The following is a description of a gene set: from publication Chen Y, Wang X (PMID 31504780) Genes predicted to be targets of miRBase v22 microRNA mmu_miR_6946_3p in miRDB v6.0 with MirTarget v4 prediction scores > 80 (high confidence targets). Mouse Gene Set: MIR_6946_3P species: Mus musculus, and this is the list of marker genes: Ttc23, Csnk1g1, Klf6, Arid1b, Kdelr1 (NCBI Gene Id 68137), Ppp4c, Lhx5, Dtx3l, Hesx1, Ercc6, Lpin2, Tmem30a, Syt11, Fgf20, Ceacam2, Zmynd8, Kcnj16, Pwwp2a, Tfec, Washc4, Oca2, Kmt2a, Gdf2, Crbn, Phactr3, Nars2, Nefh, Desi2, Rbmyf3, Dusp13b, Vim, Crppa, 1110004F10Rik, Ptger2, Nptx1, Fgf12, Pabir2, Ralgapb, Ap1m2, Fam20b, Svil, Zfp935, Tmed5, Rbm41, Ppp4r3a, Zranb2, Scn9a, Smad3, Gtf2h1 (NCBI Gene Id 97364), Plod2, Mtap, Morf4l2, Itgb3bp, Nmur2, Selenot, 4921539E11Rik, Rabgap1l, Atg12, Dpysl3, Chd6, Nrep (NCBI Gene Id 27528), Nrg3, Hivep3, Lin54, Chst2, Armh4, Rps6kb1, Virma, Cdh1, Kif26b, Akap17b, Anks1b, Ubr5, Arpp21 (NCBI Gene Id 94243), Arrdc3 (NCBI Gene Id 105171), Arhgap26, Emp2, Trim71, Cacna1c, Lgi2, Tmprss11e, Tmprss15, Crebrf, Cysltr1, Klhl9, Amer1, Rbpms2, Zfp91, Clec1a, Vezt, Zfp106, Usp27x, Setd7, Strbp, Grik1, Siae, Kif1b, Cxxc5, Rhoj, Nr2c1, Scd4, Adtrp, Map3k2, Itga9, Lgi1, Zdhhc12, Slc8a1, Tial1, Ankmy2 (ankyrin repeat and MYND domain containing 2), Polr2m, Tcaim, Wwc2, Sp3, Fpgt, Akap11, Purb, Kctd21, Dnajc9, Maml1, Elp1, Tab3, Egr1, Nlk, Tet3 (tet methylcytosine dioxygenase 3), Hapln1, Ptbp3, Plaat1, Chrm2, Keap1, Csgalnact2, Dph3, Map3k20, Rspo3, Nhlh2, Atp8b1, Grem2, Tspan5, Ulk2, Unc13c, Ints10, Fat3, Galnt7, Smo (NCBI Gene Id 319757), Dgkk, Rsf1, Acsl1, Ascl1, Rbmyf2, Adipor1, Nr1h5, Mitf, Reep1, Lmo4, Tnrc6b, Larp1, Rgs13, Slc5a7, Xpo1, Aadat, Lpar3, Nfrkb, Riox2, Snx27, Alk, Sgip1, Fgf10, Cxxc4, Gcm1, Sema3a, Rgs17, Rbmyf7, Tigd4, Slc1a2, Gli3, Sh3bgrl2, Cavin2, Necab1, Slc22a30, Nedd1, Cdk2ap1, Nexmif, Rufy3, Neto1, Plekha7, Prkcq, Tafa1, Ubn2, Trp53bp2, Eea1, Rnd1, Ankrd34b, Esyt2, Cdh20, Kcnd2, Usp30, Ffar3, Dcc, Cops2, Hars2, Kcnj6 (potassium inwardly-rectifying channel, subfamily J, member 6), Zfp148, Adamts6, Nrxn3, Eif2s1, Zfp518b, Cdh12, Yod1, Kdsr (3-ketodihydrosphingosine reductase), Thsd7a, Ttll7, Satb2, Slc22a28, Zpr1, Golim4, Lrp6, Lamp2, Mtpn, Tmem161b, Tc2n, Eif4e3, Chst11, Prpf18, Cd83, Poglut3, Elavl4, Atp2b2, Snapc1, Car10, Braf, Ammecr1, Tln2, Synrg, Grhl2, Btg3, Bend3, Ccpg1 (NCBI Gene Id 72278), Pmch, Ocrl, Cplx2, Cd28, Pan3, Col8a1 (collagen, type VIII, alpha 1), Pnma2, Gxylt1, Epg5, Patz1, Elovl6, Pank3, Klhl4, Ergic2, Slc5a1, Ndufb11b, Fbxo45, Slc5a3, Cutc, Dram2, Ank3, Rbmyf9, Ralgapa2, Gatd3a (glutamine amidotransferase like class 1 domain containing 3A), Zfp595, C87436, Aplf, Adamts3, Lrig2, Katnal1, Col4a4, Arl5a, Mal (myelin and lymphocyte protein, T cell differentiation protein), Fhip1b, Samt4, Epha5, Plekhh3, Elk3, Niban1, Mrpl50, Cpeb3, Cacna2d1, Ankrd17, Thrb (thyroid hormone receptor beta), Depdc1a, Prtg, Fxr1, Avl9 (AVL9 cell migration associated), Cop1, Rbmyf6, Klrk1, Timp3, Nhsl2, Macroh2a2, Ttbk2, Psmd10, Unc5c, Ddr2, Tmcc3, Gpr55, Tcf12, Kctd9, Rbmyf8, Ppargc1b, Fam98a, Irs4, Dld, Fbxl5, Jagn1, Tsbp1, Sdr16c5, Tmem207, Lsamp, Rbmyf1, Tox3, Rbms3, Zfp697, Pcdh17, Mdga2, Nr0b1, Flg2, Ago1, Senp7, Rorb, Mon2, 1700020L24Rik, Zkscan1, Togaram1, Gabrg1, Mef2c, Btrc, Lrrc8e, B3galt1, Necap1, Lhx8, Dync1li1, Ybx3, Syn2, Bcl2, Spop, Il36rn, Col27a1, Ybx1, Ilrun, Cachd1, Kcnk2, Glud1, Cdk12, Fmr1, Kctd11, Pdlim5, Azi2, Man2a1, Brpf1, Strap, Atxn7, P2ry1, Arnt, Tnrc6c, Slc40a1, Eif3e (NCBI Gene Id 16341), Rnd3, Gm11541, Cpeb2, Pcsk5, Rbmyf5, Rptn, Spred1, Smc1b, Kctd5, Zmat1, Nipa1, Fam124a, Phf14, Bicd2, D16Ertd472e, Kpna4, Acsm2, Nrk, Il22b, Cd84, Cadm2, Pknox2, Atg16l1, Pou2f1, Msl1, Neu4, Fut9, Lysmd3, Arid4b, Crim1, Lamc1, Map2k3, Ikzf2, Zfhx3, Ifi208, Raph1, Pigr, Mpz, Ppp1r9a, Rfx6, Axl (AXL receptor tyrosine kinase), Has2, Cfap58, Slc10a2, Clic5 (NCBI Gene Id 70662), Ptchd4, Prps1, Pou6f2, Setd1b, Tmed8, Robo2, Tstd2, Aass, Cmtm4, Tnfaip3, Rif1, Ifi44, Cfap74, Hipk1, Kctd7, Arpc5, Nedd4l, Invs, 2510009E07Rik, Rbmy, Itsn1, AI593442, Commd2, Zfp811, Dcaf7, Sgk3, Suv39h2, Trim65, Fam174a, Tslp, Synpr, Col6a3, Ttc14, Celf4, Sox9 (SRY (sex determining region Y)-box 9), Chsy3, Ceacam1, Trps1, Sec14l3, Ehd4, Slc33a1, Oprk1, Ddx52, Rfx7, Pomgnt1, Tubgcp4, Fas, Dlg3, Fgfr1op2, Usp15, Fnd3c2, Tmem199, Cxadr, Suz12, Ccdc70, Kcnj2, Pacsin1, Dtwd2, D630045J12Rik, Lrrn1, Hoxc13, Atp5f1c, Kcnc2, Gas1, Cp, Ccdc85a, Hjurp, Plekha8, Ttf1, Pcyox1l, Plxna4 (NCBI Gene Id 330281), Jkamp, Dmtf1l, Kcnma1, Vnn1, Rreb1, Dpyd, Usp13, 9330182O14Rik, Klhl14, Rab3c, Zfp606, Gpr101, Astn1, Tox4, Tns1 (NCBI Gene Id 98418), Kitl, Nfkb1, Ift80 (intraflagellar transport 80), Frrs1l, Cntln, Tmem129, Mfhas1, Smpd3, Flrt2, Dnajc5, Nabp1, Gsk3b, H2-T5, Ddx6, Thbs2 (thrombospondin 2), Trabd2b, Il22ra2, Stxbp5l, Tardbp, Mmp16, Gucy1a2, Trpm3, Cpsf2, Hunk, Dach1, Mbp, Prrx1 (NCBI Gene Id 98443), Slc25a5, Igf1, Cisd1, Ssbp2 (single-stranded DNA binding protein 2), Ms4a7, Ntsr1, Clec2m, Nvl, Prorsd1, Dusp13a, Gng10, Met, Cpm, Kbtbd6, Pkd2, Fry, Fryl, Exoc6, Fbxo38, Pik3ca, Esrp1, Rbm26, Lpl, Myh11, Gabpa (GA repeat binding protein, alpha), Mesp2, Slc4a10, Tnfaip8l3, Tfcp2l1, G6pc1, Tdp2, Rbm47, Ppp2r1b